Given this list of marker genes Hira, Asf1a, Asf1b, Vps72, Anp32e, Nasp, Ptma, Aplf, Myd88, Ipo9, Jdp2, Pwp1, Spty2d1, Nap1l1, Hirip3, Prdm12 (PR domain containing 12), here is a description of the gene set: species: Mus musculus Mouse Gene Set: GOMF_HISTONE_CHAPERONE_ACTIVITY Binding to and carrying a histone or a histone complex to unload or deposit it as a nucleosome. The histone can be newly synthesized or result from nucleosome disassembly (either spontaneously, or by a histone chaperone).